Given this list of marker genes Psma1, Psma5, Psmb6, Psmd12, Per1, Rps27a, Psma3, Psmc6, Per2, Psma2, Psmd13, Psmb4 (proteasome (prosome, macropain) subunit, beta type 4), Psmc1, Psma7 (NCBI Gene Id 26444), Psma6, Psma4, Ubb, Psmc4, Psmd1 (proteasome (prosome, macropain) 26S subunit, non-ATPase, 1), Psmc3, Psmc5, Psmd6, Psmb5, Psmc2, Psmb7, Psmd7, here is a description of the gene set: part of: Circadian clock electronically inferred by orthology from the curated human pathway species: Mus musculus Reactome Pathway: Degradation of CRY and PER proteins This event has been computationally inferred from an event that has been demonstrated in another species.<p>The inference is based on the homology mapping from PANTHER. Briefly, reactions for which all involved PhysicalEntities (in input, output and catalyst) have a mapped orthologue/paralogue (for complexes at least 75% of components must have a mapping) are inferred to the other species.